Given this list of marker genes MSN, SORL1 (NCBI Gene Id 6653), NF2, EZR, DTX3L, MGAT3, EGF, RDX, VEGFA, ROCK2, here is a description of the gene set: species: Homo sapiens Any process that activates or increases the frequency, rate or extent of protein localization to early endosome. Human Gene Set: GOBP_POSITIVE_REGULATION_OF_PROTEIN_LOCALIZATION_TO_EARLY_ENDOSOME